Given this list of marker genes BMPR2, PTPN14, PDPN, CCBE1, ACVRL1, SOX18, FOXC2, ACVR2B, PTPN20, PROX1 (prospero homeobox 1), MIR9-1, VEGFC, VEGFA, FOXC1, EPHA2, TIE1, CLEC14A, PPP3CB, VASH1 (vasohibin 1), FLT4, here is a description of the gene set: Human Gene Set: GOBP_LYMPHANGIOGENESIS species: Homo sapiens Lymph vessel formation when new vessels emerge from the proliferation of pre-existing vessels.